The following is a description of a gene set: Human Gene Set: GSE18791_CTRL_VS_NEWCASTLE_VIRUS_DC_18H_UP species: Homo sapiens Genes up-regulated in comparison of control conventional dendritic cells (cDC) at 0 h versus cDCs infected with Newcastle disease virus (NDV) at 18 h. The dendritic cell (DC) is a master regulator of immune responses. Pathogenic viruses subvert normal immune function in DCs through the expression of immune antagonists. Understanding how these antagonists interact with the host immune system requires knowledge of the underlying genetic regulatory network that operates during an uninhibited antiviral response. In order to isolate and identify this network, we studied DCs infected with Newcastle Disease Virus (NDV), which is able to stimulate innate immunity and DC maturation through activation of RIG-I signaling, but lacks the ability to evade the human interferon response. To analyze this experimental model, we developed a new approach integrating genome-wide expression kinetics and time-dependent promoter analysis. We found that the genetic program underlying the antiviral cell state transition during the first 18-hours post-infection could be explained by a single regulatory network. Gene expression changes were driven by a step-wise multi-factor cascading control mechanism, where the specific transcription factors controlling expression changed over time. Within this network, most individual genes are regulated by multiple factors, indicating robustness against virus-encoded immune evasion genes. In addition to effectively recapitulating current biological knowledge, we predicted, and validated experimentally, antiviral roles for several novel transcription factors. More generally, our results show how a genetic program can be temporally controlled through a single regulatory network to achieve the large-scale genetic reprogramming characteristic of cell state transitions. from publication Zaslavsky E, Hershberg U, Seto J, Pham AM, Marquez S, Duke JL, Wetmur JG, Tenoever BR, Sealfon SC, Kleinstein SH (PMID 20164420), and this is the list of marker genes: IL21R, SLC8B1, ACSS2, NIP7, MRPS28 (mitochondrial ribosomal protein S28), ABCD3, POLR2L, DCAF4, ENDOG, TPRG1L, PITPNA, CORO1A, EFCAB14, ATPSCKMT, PXMP4, CMTM4, CAMK1, TTLL1, AP2S1, MRPL24, USP38, IKBIP, ARHGAP12, NDUFS2, DAAM1, TCHP, PDIK1L, ITPA, NELFCD, PNP, CETN2, KIF16B, GTF3C2, PHAX (phosphorylated adaptor for RNA export), DHX30, TFPT, BCR, FAM98B, NDUFAB1, ZNF559, COPS4, WNT5B, KBTBD7, BAP1, DHFR, RMDN1, CRH, ABHD15, PAAF1, BRI3BP, PTK2, TFDP1, IMPDH2, EFTUD2 (elongation factor Tu GTP binding domain containing 2), SUOX, ARRB1, ALDH16A1, HSBP1, AP3M1, RASSF2, POLR3B, MTMR12, CCT6A, GTF3C3, VAMP3, ETV5, AHCY, TSHZ1, SLC25A12, TUBB6, FAM78A, TMEM45B, DOK2, HYCC1, UBAC1, HIP1, PPIL1, NDUFA8, CWC27, AIFM1, PDZD11, FLAD1, NDUFS3, TRMT1, TK2, MRPL16, DIS3L, CDC40, FLVCR2, METTL25, FBXW11, NHLRC2, HCFC2, STUB1, STAM, EDC3, GPATCH1, CCT3, RNF14, HECTD1, POP5, PET117, XXYLT1, NACC2, ACOT7, PMPCA, B3GAT3, PET100, TIMM21, DUS2, SPRED1, MBTPS1, WDR36, MRPS9, MRPS6, KCTD21, GEMIN6, OSGEPL1, SNAPC5, DESI2, TMEM245, MRPL12, ZNF641, NF2, G2E3, SMIM15, JKAMP, GBA2, RNF141, PPP2R1B, SERAC1, STRADB, PREP, POLR2G, TMEM170B, ELOVL1, ROGDI, TMEM273, ACTL6A, FBXO45, ATG4A, ERI1, MYCBP, SMARCC1, KLHDC3, RUNX1, BLOC1S4, GNPDA2, RXRA, TARBP2, NCAPH, FA2H, AKTIP, DNMT1, ZNF185, STAM2, PHF14, FBXO21, DCAF13, MPPE1, URB2, INTS4, TMT1A, DPP3, CSTPP1, ROCK2, DNAJC11, ATPAF1 (ATP synthase mitochondrial F1 complex assembly factor 1, NCBI Gene Id 64756), SLC26A2, IL16, RNGTT, TRPV2, ASB13, MTFR2, HVCN1, TNRC18, IPO8, XPR1, INTS8, KIDINS220, EIF4EBP2, RTN4IP1, MFSD5, TSPAN15, HSD17B10, NRROS, RPA1, CYP4V2, YLPM1, VAMP8, TBCE, CCT4, IDE, UMPS, TTI1, PHB2, PPP1R16B, PEX1